The following is a description of a gene set: studied in species Homo sapiens Human Gene Set: GOMF_CLATHRIN_LIGHT_CHAIN_BINDING Binding to a clathrin light chain., and this is the list of marker genes: HIP1, HIP1R, CALY, NSG1, CLTC, CLTCL1, NSG2